Given this list of marker genes PRKCG, HARS1, HINT1, SLC33A1, WASHC5, SPART, REEP2, KPNA3, SCO2, XK, VCP, KLC2, ALDH18A1, SPG7, BSCL2, KCND3, DARS2, SAMD9L, NIPA1, CYP7B1, SACS, TDP1, UCHL1, RTN2, AMPD2, PDK3, CPT1C, SPAST, PMP22, KLHL9, B4GALNT1, KIF5A, PEX6, IMPDH2, VAMP1, POLR3A, ATL1, GBA2 (NCBI Gene Id 57704), MT-ATP6, ABCD1, ERLIN2, WDR48, SPG11, NR4A2, CACNA1G, GCH1, PDYN, UBAP1, FLVCR1, HSPD1, FLRT1, ARSI, SPTLC2, here is a description of the gene set: Impaired vibration sensation in the lower limbs A decrease in the ability to perceive vibration in the legs. species: Homo sapiens Human Gene Set: HP_IMPAIRED_VIBRATION_SENSATION_IN_THE_LOWER_LIMBS